The following is a description of a gene set: studied in species Mus musculus Foxp3+CD4+CD25+ regulatory T (T(reg)) cells are essential for the prevention of autoimmunity. T(reg) cells have an attenuated cytokine response to T-cell receptor stimulation, and can suppress the proliferation and effector function of neighbouring T cells. The forkhead transcription factor Foxp3 (forkhead box P3) is selectively expressed in T(reg) cells, is required for T(reg) development and function, and is sufficient to induce a T(reg) phenotype in conventional CD4+CD25- T cells. Mutations in Foxp3 cause severe, multi-organ autoimmunity in both human and mouse. FOXP3 can cooperate in a DNA-binding complex with NFAT (nuclear factor of activated T cells) to regulate the transcription of several known target genes. However, the global set of genes regulated directly by Foxp3 is not known and consequently, how this transcription factor controls the gene expression programme for T(reg) function is not understood. Here we identify Foxp3 target genes and report that many of these are key modulators of T-cell activation and function. Remarkably, the predominant, although not exclusive, effect of Foxp3 occupancy is to suppress the activation of target genes on T-cell stimulation. Foxp3 suppression of its targets appears to be crucial for the normal function of T(reg) cells, because overactive variants of some target genes are known to be associated with autoimmune disease. Human Gene Set: MARSON_FOXP3_TARGETS_STIMULATED_DN Genes with promoters bound by FOXP3, dependent on it, and down-regulated in hybridoma cells stimulated by PMA and ionomycin. from publication Marson A, Kretschmer K, Frampton GM, Jacobsen ES, Polansky JK, MacIsaac KD, Levine SS, Fraenkel E, von Boehmer H, Young RA (PMID 17237765), and this is the list of marker genes: LTB, MAPKAPK3, PLIN2, PPP1R13B, FOXO3, TEC, DNAJB4, NOL4L (nucleolar protein 4 like), RAMP1, CPEB2